Given this list of marker genes ADA2, ADA, PNP, XDH, MAPDA, here is a description of the gene set: studied in species Homo sapiens Human Gene Set: GOBP_INOSINE_METABOLIC_PROCESS The chemical reactions and pathways involving inosine, hypoxanthine riboside, a nucleoside found free but not in combination in nucleic acids except in the anticodons of some tRNAs.